Given this list of marker genes CCDC47, ITGB4, ALOXE3, CDH1, POLR3A, DHODH, ABHD5, UROD, XPC, ERCC3, ZFX, ITGA6, RNF113A, NIPAL4, PNPLA1, UROS, KDM6A, ERCC6, DBR1, ALOX12B, MEGF8, RNU4-2, EFEMP1, IPO8 (importin 8), GTF2E2, MBTPS2, EDN1, TARS1, ERCC4, KMT2D, RNF2, SDR9C7, FERMT1, HNRNPK, CERS3, ABCA12, PLEC, AARS1, POLH, CD28, TWIST2, ERCC5, FLI1, ERCC2, CDC42, TGM1, DLX4, ASPRV1, XPA, CTCF, GBA1, MPLKIP, CARS1, KRT10, FOXC2, KMT2A, GRIA3, RNU12, CYP4F22, SULT2B1, ADNP, GTF2H5, TNFRSF1B (TNF receptor superfamily member 1B), LRP4, CTLA4, RIPK4, APC, ABCA1, GATA1, CARD14 (caspase recruitment domain family member 14), CTNND1, DDB2, FOXL2, LIPN, here is a description of the gene set: studied in species Homo sapiens Human Gene Set: HP_ECTROPION Ectropion An outward turning (eversion) or rotation of the eyelid margin.